The following is a description of a gene set: electronically inferred by orthology from the curated human pathway This event has been computationally inferred from an event that has been demonstrated in another species.<p>The inference is based on the homology mapping from PANTHER. Briefly, reactions for which all involved PhysicalEntities (in input, output and catalyst) have a mapped orthologue/paralogue (for complexes at least 75% of components must have a mapping) are inferred to the other species. part of: L1CAM interactions studied in species Mus musculus Reactome Pathway: Recycling pathway of L1, and this is the list of marker genes: Numb, Rdx, Ap2m1, Tuba4a, Ap2s1, Tuba1c, Tuba3b, Tubb4b, Tuba1b, Ap2b1, Tubal3 (tubulin, alpha-like 3), Tuba8 (tubulin, alpha 8), Ap2a1, Tubb2b, Dpysl2, Dnm2, Tubb6, Tuba1a, Tubb4a